The following is a description of a gene set: studied in species Mus musculus Mouse Gene Set: chr1G2, and this is the list of marker genes: Gm8964, 1700025G04Rik, Tsen15, Btf3-ps14, Colgalt2, Gm7278, Gm25279